The following is a description of a gene set: The 80S ribosome dissociates into free 40S (small) and 60S (large) ribosomal subunits. Each ribosomal subunit is constituted by several individual ribosomal proteins and rRNA. Reactome Pathway: Formation of a pool of free 40S subunits part of: Cap-dependent Translation Initiation species: Homo sapiens, and this is the list of marker genes: RPLP1, RPL37A, EIF3C, 18S rRNA, RPL7, RPL13, RPL11, 28S rRNA, RPL6, RPL35A (ribosomal protein L35a), RPL22, RPL37, RPS4X, EIF3B (eukaryotic translation initiation factor 3 subunit B), RPL34, RPL26, RPS23, RPS7, RPL5, RPLP2, RPL23, RPL22L1, RPL7A, RPS10, RPL19, RPL10A, RPS8, EIF3K, RPL35, 5.8S rRNA, RPL12, RPS15A, RPS27, RPS11, EIF3L, RPL38 (NCBI Gene Id 6169), RPS3A, RPL32, EIF1AX, EIF3I, RPS19, EIF3F, RPS6, RPL15, RPL30, RPL26L1, RPS13, RPL17, RPL3L, RPL8, RPS2, RPL36, RPL27A, RPS4Y1, RPS28, RPL39L, RPL36A, RPS5, RPS18, RPS14, RPL4, RPL14, EIF3J, RPL39, RPS17, EIF3H, RPL36AL, RPS27A, EIF3E, RPS12, RPL21, RPL18, RPS25, RPS27L, RPS15, RPL31, EIF3G, RPL24, RPL10, RPL28, RPL13A, RPL9, RPL27, RPS24, RPS16, RPL41, RPS4Y2, 5S rRNA, RPS26, EIF3A, RPLP0 (ribosomal protein lateral stalk subunit P0), EIF3M, RPS29, RPL23A, RPS9, UBA52, RPS21, RPL10L, RPS20, RPS3, RPSA, EIF3D, RPL3, FAU, RPL18A, RPL29